Given this list of marker genes RPS14, GPSM3, SLC22A7, RPL38, RHCG, ZNF532, KRT18, FEM1B, ITPK1, RBM7, CERS2 (NCBI Gene Id 63903), CBLC, SH3BP2, RPL13, CLDN7, CITED1, NCOR1, DOP1B, METTL25B, ZNF428 (NCBI Gene Id 126299), TRIM23, C6orf47, ZNF692, PSKH1, H4C11, CNPY3, MIPEP, GLT8D1, USPL1, SLC48A1, CD83, TMEM53, PRDM4, ZBTB39, SIGLEC7, PDP1, LIPE, CLCN4, TNFRSF1B, KLF3 (KLF transcription factor 3), RNF126, CAPN10, TSPAN32, CDK14 (cyclin dependent kinase 14), RNF167, SNX2, RHOB, FARP2, DCHS1, P2RY14, KAT6A, ABCC10, BBS9, LDOC1, FAAP100, SNHG32, GORASP1, TRAPPC14, FGF2, RPL30, C11orf68, ATP10D, TAGLN2, CLUAP1, ASB8, NSA2, SH3BGRL3, RRAS, RPS6KB2, AHSG, RPS18, GCNT4, GAP43, HSD17B8, RIC3, NCK2, MUL1, CTDSP1, TMEM9B, SETD1B, HTRA2, OVGP1, CD200, CBFA2T2, ATP11A, NCR3, AMACR (NCBI Gene Id 23600), H2AC6 (H2A clustered histone 6), PIGO, MYBPC3, RRP8, ZNF7, SFTPD, PHF1, PAIP2B, GGT1, MRM1, COL1A1, NENF, PTOV1, TLE5, SMARCD1, PKD2L1, SLC12A6, KIAA0040, CAVIN3, DDHD2, JARID2, IFT70A, TULP3 (TUB like protein 3), FBXW4P1, SPAG7 (sperm associated antigen 7), ANKZF1, NUDT18, KLF2, SNX15, RLIG1, PAOX, KLRC3, ABHD10, DHPS, PTPRU, SH3BP5, SELL, HSPB1, OVOL3, BAZ2A, CA11 (carbonic anhydrase 11), MUC7, NUCB1, ZMYM3, CXCL5, RNF220, FAM131B, EIF4A2, MSL1, GRAP2, RPL23AP53, GLB1L2, HLA-B, ZNHIT2, NEK9, PEMT, HAPSTR1, CTSF, H1-10, TSR2 (TSR2 ribosome maturation factor), DBNDD1, ASIC2, CES2, UBE2O, JUN, SLC4A2, FXYD1, NAGPA, C11orf21, DGCR2, CAPN2, ZNF324, ARMH3, HMGN4, XKR8, REX1BD, DCAF1, PDK2, NAAA, IFNAR1, TUBB7P, FKBP4, ZNF510, LAMC1, TP53I11, KLHL9, FOXJ2, MAGEA10, CSNK1G3, UBE2Z, HSPA1A, MAN2A2, GPATCH1, PODXL2, CTBP1, LRFN3, PCBP4, CRYAA, TXNL4B, PI4KB, APBB3, RAB4B, PHKA2, TATDN2, HDAC5, ADCY1, BTD, TSHZ2, NSUN5P2, PEX14, IFT88, CD180, here is a description of the gene set: B cells from human tonsil and blood were sorted using flow cytometry. The human samples were processed immediately ex-vivo using markers for known B cell subsets. species: Homo sapiens Human Gene Set: GSE12845_IGD_POS_BLOOD_VS_PRE_GC_TONSIL_BCELL_UP Genes up-regulated in comparison of IgD+ B cells from peripheral blood versus CD19 pre-germinal center tonsil B cell from publication Longo NS, Lugar PL, Yavuz S, Zhang W, Krijger PH, Russ DE, Jima DD, Dave SS, Grammer AC, Lipsky PE (PMID 19023113)